The following is a description of a gene set: Although VEGF-targeted therapies are showing promise, new angiogenesis targets are needed to make additional gains. Here, we show that increased Zeste homolog 2 (EZH2) expression in either tumor cells or in tumor vasculature is predictive of poor clinical outcome. The increase in endothelial EZH2 is a direct result of VEGF stimulation by a paracrine circuit that promotes angiogenesis by methylating and silencing vasohibin1 (vash1). Ezh2 silencing in the tumor-associated endothelial cells inhibited angiogenesis mediated by reactivation of VASH1, and reduced ovarian cancer growth, which is further enhanced in combination with ezh2 silencing in tumor cells. Collectively, these data support the potential for targeting ezh2 as an important therapeutic approach. Human Gene Set: LU_EZH2_TARGETS_DN species: Homo sapiens from publication Lu C, Han HD, Mangala LS, Ali-Fehmi R, Newton CS, Ozbun L, Armaiz-Pena GN, Hu W, Stone RL, Munkarah A, Ravoori MK, Shahzad MM, Lee JW, Mora E, Langley RR, Carroll AR, Matsuo K, Spannuth WA, Schmandt R, Jennings NB, Goodman BW, Jaffe RB, Nick AM, Kim HS, Guven EO, Chen YH, Li LY, Hsu MC, Coleman RL, Calin GA, Denkbas EB, Lim JY, Lee JS, Kundra V, Birrer MJ, Hung MC, Lopez-Berestein G, Sood AK (PMID 20708159) Genes down-regulated in SKOV3ip1 cells (ovarian cancer) upon knockdown of EZH2 by RNAi., and this is the list of marker genes: RPA2, CLDN1, SLC35A3, PI4K2B, TGFBR2, SLC36A1, TRIM13, NBPF14, ARHGEF10, TDRD1, PLSCR4, EXT2, ELOVL6, TUBA3FP, NBPF11, DTWD2, SULT1A1, IGFBP1, DCP2, TBC1D8B, DNAAF5, RTN3, APAF1, HNRNPUL1, SLC16A10, BCLAF1, MBD4, CTR9, SHQ1, BTAF1, CCBE1, KPNA3, TSEN2, OTX1, FKBP14, ZBTB34, SFT2D2, TAF5, HSD17B7 (hydroxysteroid 17-beta dehydrogenase 7), NPC1 (NPC intracellular cholesterol transporter 1), GOLGA8B (NCBI Gene Id 440270), SLC25A51, STAG3L3, RBM12, IGF2BP3, LAMC2, SCCPDH, TSPYL2, SEC24D, RABGEF1, GORASP2 (NCBI Gene Id 26003), CPSF6, PARD6G, POGLUT1, HNRNPU, SEC24B, INIP, PPTC7, RNF38, CCDC91, NIPA2, TMED10, NABP1, PNPT1, MTMR9, FZD1, USP49, CHCHD3, NPIPB13, PCNP, DKK1, NBPF10, ADGRG6, WASL, DENR, IDI1, RAB11FIP2, GNA13, OCIAD1, POLQ, HYLS1, DNAJC13, SKP2, DUSP19, NEU1, MCMDC2, TRAPPC11, ZNF493, GAD1, STIL, BLZF1, SDCBP, BIRC2, SLC7A7, RETREG1, NPIPB4, NLRP3, TMTC4, RASSF5, MOK, ACO1, ASCC3, NHLRC3, TMEM87A, TM7SF3, EGFR, TNFSF15, NSUN2, FAR2, TMEM17, COL3A1, ZNF280D, ANTXR1, CRCP, KLHL12 (kelch like family member 12), SLC44A4, CACHD1, AGO2, CDKN2AIPNL (NCBI Gene Id 91368), PURA, DCAF12, ZNF611, CASP2, AAK1, ORC6 (origin recognition complex subunit 6), DLEU2, CLK2 (CDC like kinase 2), TPGS2, WDFY2, LHFPL6, FAM234B, CREB1, SLC22A4 (NCBI Gene Id 6583), NFKBIZ, ADIPOR1, XIST, CENPQ (centromere protein Q), RRP1B, AMY1B, PRP4K, HEG1, TRIM63, HPRT1, TACC1, SLC16A9, RNASEL, SRPX, PPP3CA (protein phosphatase 3 catalytic subunit alpha), PM20D2, RFTN1, DYNC1LI2, PLAT, PPP1CC, EIF4G2, PI4KA, ANKRD13D, TERF1, ADM (adrenomedullin), MANEAL, ALPK2, DDX51, TECPR1, UTP3, SUGP2, ANKRD46, VWA8, JADE3, RAPH1 (Ras association (RalGDS/AF-6) and pleckstrin homology domains 1), HYPK, MSANTD2 (Myb/SANT DNA binding domain containing 2), ACSL1, FSTL1, EXOC8, SENP2, ZNF682, SLC7A6, MGAT2, PILRB, CMTM4, AMER1, PTPRE, RPIA, GFPT1, UBE2E3, ENTPD4, SCML1, IRS2, TAP2 (transporter 2, ATP binding cassette subfamily B member), MAGT1, PHACTR4, ANKRD36C, SLC35E1, SHISA2, ARMH4, SPTLC1, TNFRSF25, SHROOM4, LINC00114, TNFAIP3 (NCBI Gene Id 7128), NBPF3, ATP2B1, PSMG1, CCNE1, ZNF549, DUSP6 (dual specificity phosphatase 6, NCBI Gene Id 1848), SGCB (sarcoglycan beta), SEC63, COL4A1, JMJD7-PLA2G4B, LIMCH1, THBS1, RTCA, GRAMD2B (GRAM domain containing 2B), PALLD, ADAMTS1, IL10, BCL9, MMP3, RUFY1, PHLPP2, SACM1L, VKORC1 (NCBI Gene Id 79001), POC1B, NR2C1, ZCCHC9, ATP11C, FAM120A, TRGV5, KPNA2, ATP2C1, PSMD6, STAMBPL1, CALD1, RECK, KCNH6, GJC1 (gap junction protein gamma 1), ZNF514, CNTNAP1, BACE2, DICER1, EZH2, CYP24A1, NUDT11, ARMCX1, ATP2A2, LITAF, ZNF483, EIF1AD (eukaryotic translation initiation factor 1A domain containing), DYRK2, FAM169A, LPXN, LAMB1, SH2B3, TMEM154, CCN2, NPL, FHIP2A (FHF complex subunit HOOK interacting protein 2A), IL17RD, CFAP74, AOC4P, ESM1, CCR6, TMEM267, CDK5R1, SCML2, MTF2, GLRX, KLHL29, CYFIP2, RAB5IF, CBFB, XPNPEP3, ASB13, SH3D19, PRDX6, SLC38A1, LRRC57, BMP6, CSNK2A2, ZNF14, NLRP8, DCAF12L1, RPS6KA2, ETS1, SATB2, AXL, DLAT, TACC2, GRB14, CBLN2, LRIG1, MAGED1, SERPINH1, DIPK2A, DSG2, XRCC2, ACVR1B, BMPR2, ANKRD17, SNORA32, CRK, HMGCR, TMEM185B, CTNNA1, DDX52, SCO1, MIGA1, MTRR, EXO5, ZFYVE26, P3H2, ABCC5, PLAU, PPP2CB, MAN2A1, HNF1B, SSR3, LILRB3, NIPAL3, ALPP (NCBI Gene Id 250), SEC24A, PDE4C (phosphodiesterase 4C), METTL21A, PBK, RUNDC1, NFE2L3, FBN2, PIGM, PSMD12, GTF3C2, GLCE, SNORD14B (NCBI Gene Id 85388), SLC15A4, GUSBP18, TMX3, MCCC2, ELL2 (elongation factor for RNA polymerase II 2), ENAH, TROAP, TMEM183A, ELF4, ANLN, CCNG1, DDAH1, SLC39A11, VCL, DYNLT3, N4BP2, SEPSECS, DMC1, PICALM, WDHD1, MCL1, SPDYE2B, MYLK, TAB3, ZNF614, LAMC1, C6orf120, GOLGA8CP, NRBF2, ALDH6A1, ASRGL1, RBFOX2, IGSF3 (NCBI Gene Id 3321), LRATD2, HBEGF, TRIM33, LRP8, CXADR, TFDP1, FAM83D, OIP5, ATP2B4, DNAJC28, PAPSS2, MYBL1, MAGED2, ITPK1-AS1, LRBA, LINC01720, CHRNA5 (cholinergic receptor nicotinic alpha 5 subunit), SRSF6P2, SNAPC3, MTPN, FMC1, SEMA3C, CLDN11, HK2, CHP1P2, GPC4, ATRN, ASPH, PAIP1, RAB11FIP1, IGFBP3, PTPN12, CREB5, NBEA